Given this list of marker genes NHEJ1, PEMT, CYP2J2, PLIN1, MASP2, SUOX, CA14, CRYL1, GOT2, SLC2A9, CYP4F2, ALDH3A2, GLUL, PAOX, FMO4, HPD, PIPOX, EPHX1, CYP27A1, CRAT, APOC4, ALAS1, CPS1, SLC35A2, PCYT2, CSAD, SLC25A15, ACADSB, ACAA1, ADH6, LDLR, ECI1, DCXR, ACY1, PLPP3, SARDH, POR, CYP4F12, ACOX2, CYP3A43, PCTP, CA5A, APOL6, C4BPA, PPARA, PAH, DAO, PC, ECHS1, ALDH1L1, CYP4F3, C4BPB, TTPA, SLC2A2, QDPR, EPHX2, G6PC1, MTTP, GLUD1, CYB5A, BPHL, GPT, ACSL5, HGD, CYP2E1 (cytochrome P450 family 2 subfamily E member 1), HSD17B4, CAT, SULT2A1, AASS, MAT1A, APOC3, ADH5, PCK2 (phosphoenolpyruvate carboxykinase 2, mitochondrial), SULT1B1, HNF4A, GCDH, ADH1B, SERPING1, here is a description of the gene set: from publication Woo HG, Park ES, Cheon JH, Kim JH, Lee JS, Park BJ, Kim W, Park SC, Chung YJ, Kim BG, Yoon JH, Lee HS, Kim CY, Yi NJ, Suh KS, Lee KU, Chu IS, Roskams T, Thorgeirsson SS, Kim YJ (PMID 18381945) PURPOSE: The poor prognosis of hepatocellular carcinoma (HCC) is, in part, due to the high rate of recurrence even after curative resection of tumors. Therefore, it is axiomatic that the development of an effective prognostic prediction model for HCC recurrence after surgery would, at minimum, help to identify in advance those who would most benefit from the treatment, and at best, provide new therapeutic strategies for patients with a high risk of early recurrence. EXPERIMENTAL DESIGN: For the prediction of the recurrence time in patients with HCC, gene expression profiles were generated in 65 HCC patients with hepatitis B infections. RESULT: Recurrence-associated gene expression signatures successfully discriminated between patients at high-risk and low-risk of early recurrence (P=1.9 x 10(-6), log-rank test). To test the consistency and robustness of the recurrence signature, we validated its prognostic power in an independent HCC microarray data set. CD24 was identified as a putative biomarker for the prediction of early recurrence. Genetic network analysis suggested that SP1 and peroxisome proliferator-activated receptor-alpha might have regulatory roles for the early recurrence of HCC. CONCLUSION: We have identified a gene expression signature that effectively predicted early recurrence of HCC independent of microarray platforms and cohorts, and provided novel biological insights into the mechanisms of tumor recurrence. Human Gene Set: WOO_LIVER_CANCER_RECURRENCE_DN Genes negatively correlated with recurrence free survival in patients with hepatitis B-related (HBV) hepatocellular carcinoma (HCC). species: Homo sapiens